The following is a description of a gene set: Human Gene Set: MODULE_36 species: Homo sapiens Genes in the cancer module 36., and this is the list of marker genes: CBS, GUSBP14, PER2, TTLL4, CBY1, AMY2B, MMP9, ACOX1, ZSCAN9, PCNA, ME2, SPIB, NUP88, ACOT13, MED1, CASP9, CLP1, TMEM131L, PROS1, AGGF1, NECTIN3, HOPX, CTBS, TSN, PPM1A, DHRS12, TRAK1, PDE4D, SPEN, POLR3C, CREBL2, PPM1B, KCNK1, COQ2, MORC2, ATP6AP2, GTF2H1 (general transcription factor IIH subunit 1), KRR1, RBM12, PEX2, DAPK1, CBL, ZNF189, POLRMT, UPF2, CELSR3, TRIM23, ARIH1, SLC35D1, ZNF821, HRG, PLAGL2, FPGT, USP2, CDS2, ATP2B4, MAGI2, ZNF117, BCAR3, GUCY2D (NCBI Gene Id 8145), AMPH, RNF114 (ring finger protein 114), STX8, RBBP6, GALC, ARPP19, TCFL5, ANP32E, PIAS3, ASH2L, FLRT2, UCHL3, PIBF1, CRABP2, BORCS8-MEF2B, RALGPS1, E2F3, RCN2, GPRC5B, UBE2E1, ATP5MG, KLK6, CCNG1, CDKN1B, SCYL3, SLC26A2, TCAF1, SNRPD3, MBD1, COG5, NCF2, EED, TEP1, SKIC3, PROM1, H1-3, PLXNC1, NSMAF, MTMR11, CLASRP, ORC5, FKBP5, NFYA, SLC27A2, HAT1, EXOSC10, SURF2, RAB3GAP2, GUCA2B, RRM1, TM2D1, NCOA2, ATP6V1C1, SRPK1, LPIN2, EEF1E1, NIPBL, TDG, CENPC, CYB5B, RPGR, BRD1, KLHL20, TP53TG1, ADNP2, AGA, RNASE2, PRH1, PARG, BAZ1A, TRIP12, ADAM10, ACVR2A, CA5BP1, DLAT (NCBI Gene Id 1737), ATP5PB (ATP synthase peripheral stalk-membrane subunit b), ME3, SYMPK, ISCA1, HNMT, SRSF3, BARD1, NINL, KRT15, SNTA1, ZNF646, PHYH, ALKBH1 (NCBI Gene Id 8846), SNRNP40, GTF2B, HSPA13, PHF3, SLC25A12, ARF6, ABAT, TJP2 (tight junction protein 2), FLAD1, DYNC2LI1, CSRNP2, ITGB1BP1, MEIS2, ETV5